Given this list of marker genes Prkar1a, Abcc8, Gng12, Kcnj11, Gngt2, Adcy5, Gnb4, Gng13, Taldo1, Prkab2, Itpr2, Kcns3, Kcng2, Adipor1, Gng7, Plcb1, Gng11 (NCBI Gene Id 66066), Adra2a, Rapgef4, Cacnb2, Cacna1a, Gnai2, Adra2c, Gngt1, Cacna2d2 (NCBI Gene Id 56808), Gna11, Adipoq, Gng4, Gng8, Acsl4, Gnai1, Prkar1b, Gna15, Gng3, Plcb3, Gnb2, Gnb3, Cd36, Prkag2, Rapgef3, Tkt, Cacna1d, Slc2a1, Cacna1c, Gng10, Prkaa2, Itpr3, Gnb1, Itpr1, Gcgr, Gcg, Kcnc2, Cacnb3 (NCBI Gene Id 12297), Marcks (NCBI Gene Id 17118), Plcb2, Cacna1e, Gnaq, Prkaca, Gna14, Rap1a, Adipor2, Slc2a2, Gng2, Kcnb1, Gnas, Gnb5, Ffar1, Prkacb, Acsl3, Gng5, Adcy6, Glp1r, here is a description of the gene set: Integration of energy metabolism Mouse Gene Set: REACTOME_INTEGRATION_OF_ENERGY_METABOLISM studied in species Mus musculus